The following is a description of a gene set: Human Gene Set: GOBP_DNA_DAMAGE_RESPONSE_SIGNAL_TRANSDUCTION_BY_P53_CLASS_MEDIATOR A cascade of processes induced by the cell cycle regulator phosphoprotein p53, or an equivalent protein, in response to the detection of DNA damage. studied in species Homo sapiens, and this is the list of marker genes: GTSE1, CASP2, ATM, BCL3, CD74, SIRT1, TRIAP1, NDRG1, ACER2, NPM1, BRCA2, PPP2R5C, SOX4, RPS27L, MIF, CD44, ATR, ZNF385A, MDM2, TWIST1, SMYD2, MDM4 (NCBI Gene Id 4194), MARCHF7, KMT5A, ZMPSTE24 (NCBI Gene Id 10269), ING4, DYRK1A (NCBI Gene Id 1859), FOXO3, HIPK2, PRAP1, ATRX, TP53, CHEK2, NDUFS6, YJU2, COPS3, CDKN1A, DDX5 (NCBI Gene Id 1655), BATF, CDKN2A, PMAIP1, ANKRD1, KDM1A, MSX1, USP10 (NCBI Gene Id 9100), TFAP4, PTTG1IP, EEF1E1 (NCBI Gene Id 9521), GML, PML, PYHIN1, PPM1D, RBM38, ZNHIT1, MYO6, PLK3, HIC1, SPRED2, PLA2R1, SPRED1, SNAI2, PIDD1, SP100, E2F7, NBN, FOXM1, MUC1, CRADD, KAT5, RPS6KA6, CDKN1B, RPL26, PSMD10, PAXIP1, DYRK3, SNAI1, PLK2, SESN2